Given this list of marker genes Six4, Vegfa, Mmrn2, Six1, Gata3, Egf, Gdnf, Fgf2, Pik3cd, here is a description of the gene set: Mouse Gene Set: GOBP_POSITIVE_REGULATION_OF_EPITHELIAL_TUBE_FORMATION Any process that activates or increases the frequency, rate or extent of epithelial tube formation. species: Mus musculus